Given this list of marker genes Card11, Cyld, Nectin2 (nectin cell adhesion molecule 2), Prkd2, Usp12, Rab29, Ada, Ikbkg, Rps3, Usp46, Ccr7, Ubr2, Tespa1, Bcl10, Cd226, Trat1, Lipa, Cd81, Rela, Kcnn4, here is a description of the gene set: species: Mus musculus Any process that activates or increases the frequency, rate or extent of signaling pathways initiated by the cross-linking of an antigen receptor on a T cell. Mouse Gene Set: GOBP_POSITIVE_REGULATION_OF_T_CELL_RECEPTOR_SIGNALING_PATHWAY